The following is a description of a gene set: Human Gene Set: chr4p16 species: Homo sapiens, and this is the list of marker genes: GMPSP1 (NCBI Gene Id 728564), MIR943, RN7SKP36, KIAA0232 (NCBI Gene Id 9778), USP17L21, USP17L20, MRFAP1L1, FAM86MP, USP17L19, FAM193A, EVC2, USP17L28, AFAP1, VPS51P7, CYTL1, ENPP7P10, USP17L24, EVC, FGFRL1, EVA1CP1, RGS12, MIR571, NELFA, ABLIM2, HGFAC, TADA2B, GRK4, PDE6B-AS1, EVA1CP2, TACC3, ENSG00000283183, PCGF3-AS1, PSAPL1, LDHAP1, GPR78, PIGG, C4orf50, RNA5SP155, WEE1P1, GAK, RN7SKP275, USP17L10, OR7E103P (olfactory receptor family 7 subfamily E member 103 pseudogene), LRPAP1, ENSG00000302317, NKX1-1, ENSG00000300904, ENPP7P9, OR7E43P, OR7E163P, LINC02447, RNU6-204P, SLC2A9-AS1, COX6B1P5, RNA5SP152, LETM1, TMEM129, ACOX3, HTRA3, RPS3AP19, LINC02171, USP17L30, ABCA11P, SLC49A3, OR7E111FP, NOP14, ALG1L14P, USP17L12, SH3BP2, HTT, HTT-AS, SNRPCP16, TNIP2, MYL5, MAEA (macrophage erythroblast attacher, E3 ubiquitin ligase), SPON2, OR7E35P, SLC2A9, RN7SL589P, CFAP99, CFAP184, LINC01587, LINC02481, USP17L5, USP17L9P, PDE6B, HMX1, MIR548I2, USP17L15, MIR4798, ENSG00000245748, MAN2B2, NOP14-AS1, USP17L22, ENSG00000228919, RN7SKP292, LINC02517, USP17L14P, ENSG00000212458, LINC00955, LINC01396, STX18-AS1, RPS7P15, MSX1, MXD4, NICOL1, UNC93B8, PPP2R2C, DGKQ, MIR4800, LINC02498, OR7E85P, USP17L25, BNIP3P41, ZNF519P4, TMEM271, ENSG00000298837, VPS51P13, RPS3AP16, STX18-IT1, ENSG00000294286, MSANTD1, MRFAP1L2, FAM90A26, IDUA, JAKMIP1, MIR95, RPL7AP29, RN7SKP113, ZBTB49, ZNF732, CPZ, SORCS2, NSD2, ADRA2C, POLN, USP17L17, SCARNA22, DEFB108F, ENSG00000284684, ZNF876P, MIR4274, ZNF718, PCGF3 (NCBI Gene Id 253443), USP17L23, FAM53A, OR7E84P (NCBI Gene Id 79552), USP17L13, ATP5ME, ENSG00000287164, MIR3138, DEFB131A, LINC02600, CTBP1, RNA5SP154, BLOC1S4, TMEM128, SLBP, ENSG00000250915, LINC02482, ADD1 (NCBI Gene Id 118), NAT8L, WDR1, SNRPCP13, ENSG00000227189, TBC1D14, VPS51P18, STK32B, AFAP1-AS1, LYAR, DEFB130D, JAKMIP1-DT, HAUS3, USP17L18, USP17L16P, DOK7, RNA5SP153, FAM86EP, OR7E162P, GRPEL1, S100P, UNC93B4, ZNF595, ENPP7P11, USP17L29, CRMP1, USP17L11, OR7E85BP, SH3TC1, RAF1P1, WFS1, OR7E83P, ZNF518B, CLNK, CPLX1, USP17L27, OR7E99P, USP17L26, SPICP5, OR7E86P, NSG1, TMED11P, CTBP1-AS, STX18, ENSG00000307864, MIR378D1, ALG1L7P, ENSG00000288075, OTOP1, UNC93B7, ZNF721, ZFYVE28, TMEM175, FGFR3, SLC26A1 (solute carrier family 26 member 1), TRMT44, MFSD10, ZNF141, RNF4, DRD5, MRFAP1, RNF212, UVSSA, CTBP1-DT, FAM86KP, ALG1L3P, USP17L6P, ENSG00000295539